The following is a description of a gene set: Human Gene Set: IVANOVA_HEMATOPOIESIS_LATE_PROGENITOR Mechanisms regulating self-renewal and cell fate decisions in mammalian stem cells are poorly understood. We determined global gene expression profiles for mouse and human hematopoietic stem cells and other stages of the hematopoietic hierarchy. Murine and human hematopoietic stem cells share a number of expressed gene products, which define key conserved regulatory pathways in this developmental system. Moreover, in the mouse, a portion of the genetic program of hematopoietic stem cells is shared with embryonic and neural stem cells. This overlapping set of gene products represents a molecular signature of stem cells. from publication Ivanova NB, Dimos JT, Schaniel C, Hackney JA, Moore KA, Lemischka IR (PMID 12228721) species: Mus musculus Genes in the expression cluster 'Late Progenitors Shared': up-regulated in hematopoietic late progenitor cells from adult bone marrow and fetal liver., and this is the list of marker genes: WEE2, KGD4, NIN, C7orf57, CTSC, DOK3, IL13RA1, MRPL50 (mitochondrial ribosomal protein L50), SLC35A3 (NCBI Gene Id 23443), DHRS7, KIF1B, CDK5, HMBS, ZBTB18 (zinc finger and BTB domain containing 18), MGAM, CDC25B, LAMTOR3, GDA, CCR1, C18orf32, PITPNB, SPRING1, HP, FBXO33, LZIC, DNA2, NAPA, GHITM, BMP2K, EEF1D, CEMIP2, SLC45A3, KLHDC2, RBM44, RABGAP1L, CCNC, SLC33A1, SORL1, UROD, NRP1, TLK1, MET, CISD1, LIN9, MTX2, MAGOH, GPN2, ALDH3B2, SLC15A4, ABHD5, ORC4, MIR223, SEMA4D, KPNA1, SVIP, ETF1, CSNK1G3, ASAP1, TFRC, MINPP1, PITRM1, RRM2, LEFTY1, SPC25, CEP350, CASP1, SRSF1, CLEC12A (C-type lectin domain family 12 member A), PIEZO1, FCGR2B, CCDC88B, GBE1, ABCB7, LAMTOR4, NCOA4, TREX2, ASB1 (ankyrin repeat and SOCS box containing 1), CABLES2, OSGEPL1 (NCBI Gene Id 64172), KTI12, TYROBP, NECAP2, RNF115, SZRD1, MEAF6, USP24, SMCO3, TADA2B, SPIRE1, DNMT3L, MAPK7, GAL3ST2, SEH1L, RPAIN, DOCK10, ATXN10, MOB3A, LRRC20, GIN1, IPCEF1, IGLL5, TTR, ANKRD46, PSMC6, TACSTD2 (NCBI Gene Id 4070), HECTD3, SDCCAG8, PPIL1, CERS6, NEURL1, GPR89A, HAX1, PRELID3B, RGCC, S1PR4, GATC, SGMS2, ZMYND12, NSDHL, SELL (selectin L), SMAP1, CA1, RAP1A, PABIR1, C1QTNF12, ITPA, NDUFV1, HSD11B1 (NCBI Gene Id 3290), FTSJ1, AP1S2, SAT1, OAT, PIN1, KCNJ2, SLC12A4, IFI30, SOAT1, MYO5C, KATNB1, CKLF, EXOC5, SSH1, PACSIN2, OSTM1, CDC37L1, COL5A1, GPC1, WRN, TSTD3, PHF5A, ADRM1, PLIN5, USP45, ICAM4, RFESD, SLC31A2, HPF1 (NCBI Gene Id 54969), LHFPL2, ATRN, ATF6, RAB3C, EAPP, TMEM43, PLEKHF2 (pleckstrin homology and FYVE domain containing 2), UGDH, IRF8, SLC25A21, QPCTL, CLPTM1L, C5orf63, ALAD, PRSS16, HDC, MPEG1, ATP6V0B, HNRNPLL, IFRD2, NUCB2, UBE2W, MCM2, R3HCC1L, GAK, CSGALNACT2, DAD1, PRDM10, IPMK, SGK3, UBXN2A, GPR101, G6PD, WDR7, MAP3K13, DFFB, EVI2A, ALDH1A1, MRPS6, SPTLC2 (serine palmitoyltransferase long chain base subunit 2), ENO1, ALAS1, GSR, REEP1, CPTP, L3MBTL2, CDC123, SELENOI, DAP3, PTPRO, GALNT10, RNF41, TMEM50B (transmembrane protein 50B), PSMC1, TACC1, SEPTIN8, TASL, STX11, STAMBPL1, API5, RGS9, ELMOD1, TK1, SAXO2, COMMD5, CCL15, AP5M1 (NCBI Gene Id 55745), SLC14A1, MT1F, POLD1, ERI1, PTCD3, NCAPG2, CXADR, OSTF1, MS4A6A, BSG (NCBI Gene Id 682), GMCL1, EXT1, DNAJB3, MYCBP, ANXA3, GET3 (guided entry of tail-anchored proteins factor 3, ATPase), GTSF1, TANGO2, VMA21 (NCBI Gene Id 4202), FGFRL1, PRADC1, UBE2Q1, CETN3, ZEB2, TMEM167A, MAPK1, DRAM1, GAREM1, LTA4H, SLC29A1, LY86, TMEM33, TTC13, KATNBL1, TMED3, LGALS12, HECTD4, BCL2L15, KLHL32, KLF1, HLA-DMB, MAP2K4, TM9SF1, MASTL, MCTS2, TMEM14C, AP3S1, CGN, NADSYN1, TNFAIP8L2, CCDC102A, AGPS, CYBB, RGS10, HAVCR1, EAF1, FNDC3B, SAP30, RAB44, TLR1, RAB32, MTUS1 (NCBI Gene Id 57509), NUF2 (NUF2 component of NDC80 kinetochore complex), IL1RL1, PHF10, MFSD14A, MT1X, PGP (phosphoglycolate phosphatase), C5orf22, CES2, USF1, WNT4, ACER3, RNMT, APOO, XRRA1, H1-5, SAV1, RPE, ANKRD22, CCDC127, EMILIN2, LMAN1, ESCO2, SLC49A4, BAZ1A, CLEC10A, PPP4R3B, ALG8, CISD2, ANKRD28, FASTKD2, TRMT12, UMAD1, CLINT1, ATP6V0E1, GPR160, KCTD14, ASCC2, CSF2RB, C1orf162, F10, PPP2CB, ARRDC1, CTSB, UBE2V2, CRYBG2, ABCA9, BCAP29, FNIP1, TMEM19, RNASEH2B, UGGT1, CHAC1, CX3CR1, PLIN2, FGL2, DHX35, CD33, HADHB, TENT5D, FERRY3, CTSG (cathepsin G), RFWD3 (NCBI Gene Id 55159), NFIB, TIFA, EIF2S1, HCK, RAB7A, XPNPEP3, ABR, SYNRG, LTB4R, FCGR1A, CPNE8, ORMDL2, ZCCHC8, SLC25A33, ST7L, SLC38A5, FAM107B, PBK, VPS8, WAPL, GDI2, ART2BP, MTHFD1L, INSIG2, DAPL1, SPOPL, LCE3B, MTFP1, ATP9B, FUT4, INTS4, SLC22A4, TASP1, TRAPPC2L, HVCN1, SLC25A51, EXOC6, CCNB1, UBTD1, HPSE, RHOA, ADSS2, NPTN, HCFC2, CD300A (NCBI Gene Id 11314), LYST, GPR135, ARPC4, SNTB1, SP6, GGNBP2, EMC6 (ER membrane protein complex subunit 6), TROAP, SLPI, GMIP (NCBI Gene Id 51291), PTGR1, PRDX3, SNX1, SLBP (stem-loop histone mRNA binding protein), PSTPIP2, MAP2K1, ACP1, MED7, TVP23B, HCST (NCBI Gene Id 26169), EHD2, NUP205, SERBP1 (SERPINE1 mRNA binding protein 1), BIRC5, CKAP2L, GGA2 (NCBI Gene Id 23062), PRKAR2B, FDPS, CTSS, BTLA, RNF130, GMPS, TMEM248, SMIM45, ALDH3A2, ERMAP, SLC39A3, MRPL16, ANXA2, CDC6, ITGA1, ASF1B, CLP1, KCNQ3, RARB (NCBI Gene Id 5915), LPCAT2, TMX4, ELOVL7, HBS1L, SLFN12, NXPE4, ADSS1, RAG1, APEH, LYRM9, APP, ATAD5, UBAP1, BAG2, USP46, BLVRB, MAP1A, ERO1A, NSD3, SPHK1 (sphingosine kinase 1), PUS7L, KCTD7, DHX8, ATP6V1C1, POT1 (protection of telomeres 1), CPOX, TTC9C, ACOT9, ESPL1, HARBI1, MTFR1, ABCD2, UFC1, RCC1, FIGNL1, NEK3, DUSP11 (NCBI Gene Id 8446), TMEM216, TENT5A, COA5, ANKRD12, SKIC8, TSPAN33, CENPP, IDH1 (NCBI Gene Id 3417), TMEM165, BTNL9, NAPG, PPP2R1B, TMEM156 (NCBI Gene Id 80008), GLRX, F13A1, RAB31, YAE1, SLC35E1, NFU1, GDF3, DERA, USP14, MSMO1, TMED2, C19orf38, FTH1 (NCBI Gene Id 92182), CDC42, XPO5, PLEK, TWF2, CCR2, POMK, HSPBAP1 (HSPB1 associated protein 1), CLDN15, ABCB4